The following is a description of a gene set: CD4:CD8 ratio less than 1, measured either as proportion of total CD3+ T cells, or in absolute numbers per microliter. These are usually measured within the TCR alpha/beta positive population. Normally there are relatively more CD4+ than CD8+ T cells. Inverted CD4:CD8 ratio studied in species Homo sapiens Human Gene Set: HP_INVERTED_CD4_CD8_RATIO, and this is the list of marker genes: GATA2, CASP8, DEF6, CTPS1, IL2RB, RFXAP, AP3B1, UNC119, IL2RA, MAGT1, WAS